The following is a description of a gene set: Genes down-regulated in B lymphocytes versus CD8 T cells. Murine Cytomegalovirus (MCMV) infection leads to early activation of various immune cells, including B and T lymphocytes, before the actual initiation of antigen-specific adaptive immunity. This activation is partly driven by innate cytokines, including type I interferon (IFN), which are induced early after infection. The objective of this study was to address the role of type I IFN in shaping early/innate B and T cell responses to a primary acute viral infection. In order to decipher the specific impact of IFN-I on cell subsets, we performed a genome-wide expression analysis on WT splenic B and CD8 T lymphocytes isolated from C57BL/6 mixed bone marrow chimera mice. This study complements series GSE39555, which focused on early responses of NK cells and of the two subsets of conventional dendritic cells. studied in species Homo sapiens Human Gene Set: GSE45365_BCELL_VS_CD8_TCELL_DN, and this is the list of marker genes: PPP1R14A, LINC02901, MTCL1, MS4A4A, MAPKAPK3, PPBP, GPC2, WT1, LMOD1, SMIM11, FOXA2, KIAA0930, PRX, LINC02912, MS4A6E, STING1, C2, ZNF804A, TRAM2, MYOC, GP1BA, SEPTIN4, EPOP, ITGB3, CDH13 (NCBI Gene Id 1012), IGFBP2, EMP1, ZFYVE21, ZBTB8A, PRLHR, H2BC3, USP30-AS1, PALS2, SOX6, FABP1, TBPL1, BDKRB2, TREML1, FAM171B, PF4, ACOX2 (acyl-CoA oxidase 2), BCDIN3D, PKD2L2 (NCBI Gene Id 27039), SLC35E4, ARHGEF26-AS1, OSTM1, FOXC2, PIGV, STK32B, FAM9A, STARD8, UQCC1, RIPPLY2, IGFL1, F3, MBD3L1, ENSG00000281732, WSB2, LINC00474, C1QTNF2, LRRTM4, SHC4, MPV17L2, GNA14, MMP1, MYRF-AS1, VANGL1, CAVIN3, IDH1, NXN, TTC38, C3orf70, ABHD8, DBIL5P2 (diazepam binding inhibitor-like 5 pseudogene 2, NCBI Gene Id 100169989), ZNF678, TSPAN7, PHLDB1, SYN3, FAM221B, DPP10-AS1, KCNA10, KDELR3, BPY2, HSPA2, UNC45A, LRP11, EPDR1, TCEA3, CSTF3-DT, CBLN2, C22orf23, SLC25A25, ESRP2, EPHA1, NALCN, RASGRF2, C8orf74, TCEAL9 (transcription elongation factor A like 9), LINC00315, DNAH12, PTCHD3P1, CYP11B2, FOXR2, TMT1B, MFSD3, RSU1, MTMR8, TSGA10, HSD17B6, PCBD1, INF2, RPL39L, ASTN2, HIGD1A, SNTG2-AS1, ZNF503, CYP26B1, MMAB, HYLS1, IGHV1-69, C1QB (complement C1q B chain), LINC01101, PCSK2, CNN3, GUCY1A1, CFH, PDHA2, ZNF705G, IRX2, C1QC, CHL1, TSPAN33, GRAP2, KLKB1, IDO1, CRY2, CYP2A6, LRP8, NOX3, ST6GAL2, DCLK3, RAVER2, LINC00683, FMN1, ZNF80, FZD5, LCNL1, LINC01549, SEMA4C, ZNF778, RAB23 (NCBI Gene Id 64438), EREG, RHBDF1, PPME1, GSTM2, MAGI1-IT1, LGALS1, SLC66A1, LINC00029, GREP1, ACOT7, SPSB2, OR5P3, LINC01579, LINC02875, SRRM2-AS1, ZNF526, DPY19L1P1, VDR, ADAT3, SNX32, LBX2-AS1, GSTM1, COX6A1, ZMAT2, CCN2, WDR24 (NCBI Gene Id 84219), HOXB13, FBXO31, ANO2, GPR173, PPP4R3C (NCBI Gene Id 139420), HEPACAM, BAG3, TRIM49, LINC00304, NRGN, ACSF2, CA6 (NCBI Gene Id 765)